The following is a description of a gene set: Human Gene Set: HP_4_5_TOE_SYNDACTYLY studied in species Homo sapiens Syndactyly with fusion of toes four and five. 4-5 toe syndactyly, and this is the list of marker genes: CCNQ, SALL1, MAP3K20, NSUN2, NSDHL, RBBP8, NECTIN4, SF3B4, HOXD13, TELO2, TBX15, MYCN, TMEM231